Given this list of marker genes Cxcl2, Ppbp, Dapk2, Lyn, Srp54a, Ccl19-ps3 (NCBI Gene Id 65959), Mdk, Mapk3, Cx3cr1, Vegfd, Pf4, Fpr2, Aif1, Thbs1, Il12a, Syk, Edn1, Adam8, Ccl25, Csf1, Lgals9, Ccl22, Bst1, Rpl13a, Ccr6, Itgam, Ccr3, Defb25, Cxcl17, S100a14, Ccl5, Dysf, Cxcl3, Fcer1g, Cxcl12, App, Mif, Ccr1l1, Cyp19a1, Ednra, Nckap1l, Vegfb, Rarres2 (NCBI Gene Id 71660), Lgmn, Ptn, Oxsr1, Prex1, Slc37a4, Klrk1, Ccl21d, Sell (NCBI Gene Id 98392), Ctsg, Ifng, Retnlg, Nod2, Msmp (NCBI Gene Id 242407), Il23a, Mmp28 (NCBI Gene Id 237892), Wnt5a, Trem3, Gbf1, Ccl26, Mpp1, Ccl11, Mmp9, Fpr-rs7, Dpep1 (dipeptidase 1), Ccl19-ps5, Ccl21b, Pde4d, Mcu, Ccl8, Fpr-rs6, Vegfa, S1pr1, Cxcl16, Spp1, Jaml, Ccl3, Slamf1, C5ar1, Alox5 (NCBI Gene Id 232336), Gpr15lg, Ccr1, Adam10, Creb3, Nup85, Cxcl9, Gm5849, Lyst, Itga1, Sbds, F7, Tnfaip6 (NCBI Gene Id 21930), Dusp1, Mtus1, Ednrb, BC037156, Csf3r, S100a8, F2rl1, Mmp2, Lgals3, Dpp4, Ccl12, Il17ra, Thbs4 (thrombospondin 4), Cx3cl1, Tnfsf18, Edn2, Rin3, Ccl19, Ptpro, Cxcl5, Myo9b, Ccl2, Slit2, Cxcl10, Adam17, C1qbp, Cxcl11, Cyp7b1, Dnm1l, Padi2, Cxcr1 (NCBI Gene Id 227288), Cxcl14, Kit, Tmem102, Lbp, Flt1, Coro1a, Nedd9, Rac1, Slc8b1, Zfp580, Ripor2, Cxcr3, Pikfyve, Edn3, Tirap, Ccl21f, Vav1, Ppia, Pla2g7, Ano6, Gas6, Ffar2, Calr, Pdgfb, Plec, Tgfb2, Rac2, Cnr2, Gpr18, Ccl19-ps1, Itgb2l, Ccl4, Jam3, Cxcl1, Scg2, Cxcr2 (C-X-C motif chemokine receptor 2), Wnk1, Ccl7 (NCBI Gene Id 20306), Camk1d, Fcgr3, Ccl21a, Ccl19-ps4, Mstn, Vegfc (vascular endothelial growth factor C), Gpsm3, Ccl24, Fpr-rs3, Serpine1, Stk39, Itga9, Gpr183, Perp, Tnfsf14, Ccr2, Cxcl13, Ptk2b, Anxa1, Hsd3b7, Gpr35, Stap1, Cxcr5, Mospd2, Akirin1, Swap70, C5ar2, Ptk2 (NCBI Gene Id 14083), Itgb2, Mst1, Il16, Ptprj, Csf1r, Slamf8, Cxadr, Grem1, Ninj1, Fpr-rs4, Il1b, Trpm2, Bsg, Arhgef5, C3ar1, Rps19, Nbl1, Ccn3, Il4, Hmgb1, Ccr7, Slamf9, Trpv4, Prkca, Ccl19-ps6, Trpm4, Chga (NCBI Gene Id 12652), Cklf, Ccl28, S100a9, Tnfsf11, Cmklr1, Il17b, Ccl1 (C-C motif chemokine ligand 1), Ppib, Tafa4, Cxcl15, Vav3, Cd74, Ch25h, Pgf, Ccl27a, Mapk1, Pde4b, Il34, Hc, Il17rc, Trem1, Slc12a2, Ccl21e (NCBI Gene Id 100504239), Xcl1, Spi1, here is a description of the gene set: studied in species Mus musculus Mouse Gene Set: GOBP_LEUKOCYTE_CHEMOTAXIS The movement of a leukocyte in response to an external stimulus.